The following is a description of a gene set: studied in species Mus musculus Mouse Gene Set: TABULA_MURIS_SENIS_LUNG_ENDOTHELIAL_CELL_OF_LYMPHATIC_VESSEL_AGEING from publication Tabula Muris Consortium (PMID 32669714), and this is the list of marker genes: H2-D1 (histocompatibility 2, D region locus 1), H2-Aa, Ins1, Cfl1, S100a9, Rhoc, Aqp1, B2m, H2-K1